The following is a description of a gene set: Genes up-regulated 6 h after induction of HoxA5 expression in a breast cancer cell line. Human Gene Set: CHEN_HOXA5_TARGETS_6HR_UP The homeobox gene HOXA5 encodes a transcription factor that has been shown to play important roles in embryogenesis, hematopoiesis, and tumorigenesis. In order to decipher downstream signaling pathways of HOXA5, we utilized oligonucleotide microarray analysis to identify genes that are differentially expressed in HOXA5-induced cells compared with uninduced cells. Comparative analysis of gene expression changes after 9 h of HOXA5 induction in Hs578T breast cancer cells identified genes whose expression was modulated at least 2-fold. Ten of these genes were also up-regulated by at least 2-fold at 6 h post-induction. The expression of all of these genes was confirmed by semiquantitative reverse transcription-PCR. Among these genes, which are most likely to be direct targets of HOXA5, we initiated an investigation into the pleiotrophin gene by first cloning its promoter. Transient transfection assays indicated that HOXA5 can specifically activate the pleiotrophin promoter. Promoter deletion, chromatin immunoprecipitation assay, and gel-shift assays were performed to show that HOXA5 can directly bind to one binding site on the pleiotrophin promoter. These data strongly suggest that microarray analysis can successfully identify many potential direct downstream genes of HOXA5. Further functional analysis of these targets will allow us to better understand the diverse functions of HOXA5 in embryonic development and tumorigenesis. studied in species Homo sapiens from publication Chen H, Rubin E, Zhang H, Chung S, Jie CC, Garrett E, Biswal S, Sukumar S (PMID 15757903), and this is the list of marker genes: SNAI2, SAT1, ZNF20, KLF10, CXCL8, EGR1, TIPARP, IER2, GADD45B, ZNF35